The following is a description of a gene set: studied in species Homo sapiens A state of fatigue, either physical or mental slowness and sluggishness, with difficulties in initiating or performing simple tasks. Distinguished from apathy which implies indifference and a lack of desire or interest in the task. A person with lethargy may have the desire, but not the energy to engage in personal or socially relevant tasks. Lethargy Human Gene Set: HP_LETHARGY, and this is the list of marker genes: RPS27, RPL5, PIGA, MMUT, MT-ND2, MT-ATP6, PCCB, TG, NDUFS2, HNF4A, PROP1, HJV, SLC19A2, RPL11, RPS17, NODAL, PLCH1, RYR1, FOXE1 (forkhead box E1, NCBI Gene Id 7081), RMND1, ABCD4, CPT2 (carnitine palmitoyltransferase 2), RPL18 (ribosomal protein L18), ASL, ABAT, MMAB, DISP1, TPO, RPS24, SLC26A4, ZIC2, GCH1, GCSH, BCKDHB, LYRM7, MTR, NFS1 (NFS1 cysteine desulfurase), TSR2, POLG2, NDUFB3, HLCS, DUOXA2, ACADS, STAG2, TRIM8, YY1, NAXD, CA5A, BCKDHA, FOXH1, RPS26, SUGCT, GABRB2, SCN2A, LHX3, RPL15, SLC7A7, NDUFA11, IVD, GK, NDUFS4, RPS7, TGIF1, GLDC, DLL1 (NCBI Gene Id 28514), FGF8, GRIN1, ABCC8 (NCBI Gene Id 6833), ACADVL, HADHB, GRM7, ALDOB, TCN2, ATP5MK, NDUFS7, MCCC1, SCN1B, YARS2, PBX1, GNAO1, RPL35, ATP13A2, MT-ATP8, TAMM41, KCNA1, TSPOAP1, PAX8, NDUFB10, CPS1, NDUFB9, MMADHC, NDE1, NKX2-1, TFAM, PDHA1, CDKL5, HEATR3, ASPA, MT-ND1, TMEM126B, SLC19A3, DPYD, HESX1, GATA1 (NCBI Gene Id 2623), NDUFS3, NDUFAF5, MTRR (NCBI Gene Id 4552), DBT, MMACHC, RPL8, NDUFV2, NDUFAF1, SLC1A2, SIX3, HAMP, RPL26, CASK, CPT1A, DMXL2, CDKN2B, MAGEL2, SLC25A4, MRPS16, MEN1 (NCBI Gene Id 4221), EIF2B1, RARS2, PTCH1 (patched 1), NDUFS6, NDUFAF8, POLG, GAS1, NDUFAF3, HIBCH (3-hydroxyisobutyryl-CoA hydrolase), SLC22A5, RPS15A, ASS1, NKX2-5, SLC4A1, CDKN1A, TBK1, MTHFR, SLC32A1, DLD, PNKP, CYP24A1, GUF1, NAGS, RPS20 (ribosomal protein S20), HMGCL, POU1F1, NDUFA1, ARX, SCO2, KCNJ11, SLC31A1, HADH, TSHB, TH (NCBI Gene Id 7054), DPYS, RPL9, PCCA, HADHA, NUBPL, TSHR, FBP1, PAX2, HNF1A, FGFR1, COX5A, MT-ND3, RPS29, UCP2, GLI2, TLR3, GYS2, DUOX2, ACADM, SHH (sonic hedgehog signaling molecule), MCCC2, TIMMDC1, RPS19, SLC52A1, ATP5F1D, LMBRD1, ADA2, NDUFAF2, IYD, SLC25A15, MT-TT, CRIPTO, RPL35A, PIGQ, SLC39A4, BNC2, RPS10, SLC25A19, USP18, RPS28, NDUFS1, FOXRED1, NDUFA6, SLC2A1, SLC5A5, CDKN2C, ACADSB, KRT18, BMP6, NBAS, LHX4, ATP5F1E, NDUFB11, BOLA3, NDUFS8, ATPAF2, SLC25A13, AGR2, STIL, OTC, ATP5F1A, HFE, SIK1, SLC25A22, BTD (biotinidase), RPL31, SMC1A, PIGP, DDC, NFU1, MT-CYB, NDUFAF4, NEUROD2, NDUFV1, AVP, CDON, PRDX1 (NCBI Gene Id 5052), NAA10, RRM2B, PEX2, CDKN1B, RPL27, MMAA, TRHR, ALG12, COG8, SIM1, TWNK, SLC25A20, GALT